Given this list of marker genes ADAM10, NHEJ1, INHA, SLC39A7, PTPN6, BAX, FCGR2B, LGALS8, ATM, TNFSF13B (NCBI Gene Id 89794), RABL3, BCL2, AICDA, SYK, NCKAP1L, ITGB1, BCL6, PLCL2, INHBA, PIK3R3, RAG1, DDRGK1, ST3GAL1, MS4A1, IL6, PIK3CD, FZD9 (frizzled class receptor 9), PPP2R3C, ZFP36L2 (NCBI Gene Id 96706), DLL1, SPI1, MALT1, MFNG, NKX2-3, HDAC4, CYLD, MYB, ITFG2, LRRC8A, CDH17, BAK1, TCIRG1, IL2, GPS2, BLNK, PCID2, PLCG2, CR2, LYL1, NOTCH2, PHF14, PRKDC, POLM, CD40LG, XBP1, IL9, TRAF3IP2, BCL3, PTPRC, TLR9, MIR17HG, FOSL2, TOP2B, INPP5D, RAG2, HMGB3, SP3, MSH2, ID2, IL4, POU2AF1, CD79B, TAOK3, IGHM, ADA, ITGA4, IRF8, HDAC5, DOCK11, GPR183 (NCBI Gene Id 1880), IL7, ZFP36L1, IL2RG, FNIP1, SPIB, ZBTB7A, ZBTB1, DOCK10, LGALS1, ADGRG3, SLC25A5, SYVN1, SFRP1, VCAM1, DNAJB9, IL21, PIK3R1, EP300, ONECUT1, SLAMF8, JAK3, TPD52, NTRK1, BAD, C17orf99, PTPN2 (protein tyrosine phosphatase non-receptor type 2), AQP8, CMTM7 (NCBI Gene Id 112616), KIT, IKZF3, IL11, IL4I1, CD79A, FLT3LG, HDAC9, CARD11, STAT5A, IL10, MMP14, FLT3, NFAM1, TP53, TCF3, DCLRE1C, ITM2A, IRF2BP2, EZH2, CEBPG, NFKBIZ, ADAM17, LFNG, LAPTM5, STAT5B, DCAF1, HHEX, PAX5, KLF6, BTK, CD27, ABL1, CLCF1, PIK3R2, FCRL3, PTPRJ, CR1, CD19, PTK2B, YY1, RBPJ, here is a description of the gene set: Human Gene Set: GOBP_B_CELL_DIFFERENTIATION The process in which a precursor cell type acquires the specialized features of a B cell. A B cell is a lymphocyte of B lineage with the phenotype CD19-positive and capable of B cell mediated immunity. studied in species Homo sapiens